The following is a description of a gene set: Human Gene Set: REACTOME_PEPTIDE_LIGAND_BINDING_RECEPTORS studied in species Homo sapiens Peptide ligand-binding receptors, and this is the list of marker genes: F2RL3, F2R, CXCR3, PRLHR, CXCL5, OXTR, PROK2, NPFF, CCK, CXCL16, TACR1, MC1R, HCRTR1 (hypocretin receptor 1), TACR3, GRPR, XCL1, CCL16, NPBWR1, POMC, CCR1, PSAP, SSTR2, KEL, NTSR2, NTSR1, TAC3, APLN, KISS1, TRH, INSL3, CCL5, CCL20, UTS2, AGTR2, CX3CR1, AGT, HEBP1, NPY2R, CXCL1, KNG1, C3, CCKBR, ECE2, XCL2, FPR2, NMBR, PYY, RXFP4, HCRTR2, CXCL9 (NCBI Gene Id 4283), MLN, SSTR4, ACKR1, CCL1, CCL13, CXCL13, RXFP3, OPRK1 (NCBI Gene Id 4986), MC4R (melanocortin 4 receptor), EDNRB, CXCR5, PMCH, CXCR2, MC5R, GPER1, F2RL2, HCRT, EDN3, PDYN, QRFPR, NMS, NPS, CCL2, SSTR1, UTS2R, NLN, OPRD1, KISS1R, C3AR1, NPBWR2, AGTR1, GALR3, GALR2 (galanin receptor 2), FPR3, CXCL12, SSTR3, OPRL1, ECE1, CCR6, F2, NPFFR1, NPY4R, CCL19, CCL11, RXFP2, OXT, MCHR1, TACR2, APLNR, ACKR3, ACKR4, CXCL6, NPFFR2, RLN2 (NCBI Gene Id 6019), PPY, RXFP1, EDN1, CCL25, INSL5, SAA1, NMU, AVPR2, NPY, MLNR, PRLH, GPR37, NMUR1, GRP, XCR1, TRHR, GALR1, MC2R, NPSR1, UTS2B, F2RL1, ACKR2, PROKR1, CCL23, CCR4, CCL17, QRFP, CCL21, GAL, GHSR, CCR10, NMUR2 (NCBI Gene Id 56923), AVPR1A, PPBP, NPY1R, C5, CCR9, BDKRB2, NPB, PNOC, CCL3, SSTR5, PROK1, XK, CCL27, GHRL, NMB, CXCL10, MC3R, C5AR2, EDNRA, ANXA1, TAC1, CXCL3, CXCL11, CXCR1, CCL4, CCL22, CCKAR, CCL7 (NCBI Gene Id 6354), BRS3, C5AR1, CCR3, CXCL2, PF4 (NCBI Gene Id 5196), CORT, AVPR1B, AVP, CCR5, RLN3, CCR8, CXCR6, CCR2, EDN2, CCL28, CXCL8, CCRL2, FPR1, CCR7, GPR37L1, PENK, CXCR4, NPY5R, NTS, CX3CL1, MCHR2, NPW, APP, BDKRB1, PROKR2, OPRM1, SST, CCL3L3